Given this list of marker genes PTEN, PRKCD, NFKB1, PTK2, STAT1, CDKN1B, CLDN7, IGF2R, IGF2, PIK3R1, CCND1, ITGA5, ITGB1, ACVRL1, VIM, CDKN2A, EGFR, JUN, ADAM10, CLDN1, BAX, NOTCH1, ADAM17, CDH1, MDK, FN1, PRKCA, CDK2, PAK4, RACK1 (NCBI Gene Id 90938), RAC1, IGF1, PECAM1, ABCC1, SRC, IGF1R, NUMB, BCL2, JAK2, PSEN2, MMP13 (matrix metallopeptidase 13), CTNNB1, CDK4, TACSTD2, CHEK1, TLN1, CCNE1, PSEN1, RB1, here is a description of the gene set: TROP2 regulatory signaling Human Gene Set: WP_TROP2_REGULATORY_SIGNALING species: Homo sapiens